The following is a description of a gene set: Human Gene Set: GOMF_TUMOR_NECROSIS_FACTOR_RECEPTOR_BINDING studied in species Homo sapiens Binding to a tumor necrosis factor receptor., and this is the list of marker genes: SIVA1, TRAF3, TRAF2, TNFSF8 (NCBI Gene Id 944), TNFSF15, TNFSF4, TNFSF10, TRAP1, FADD, TRAF1 (TNF receptor associated factor 1), LTA, STAT1, TNFSF11, TRAF4, TNFSF12, TNF, BABAM2, TRAF6, TNFSF9, CD40LG, TRAF5, LTB (lymphotoxin beta), TNFSF13, CASP8, TRIM37, TNFSF13B, CD70, FASLG, EDA, TNFSF14